Given this list of marker genes INTS8, ZNF395, TUBA4A, PTPRO, SAMM50, MRPL34, PDE5A, MRPS6, MTERF4, SLC25A36, TIGD2, MLLT10, VGLL4, COQ5, LBHD1, AGAP1, SPSB2, HDGFL2, PRMT9, REG1B, PDE4A, TBC1D2, THADA, SLC20A1, NVL, TACSTD2, ARHGEF40, MBP, RHOBTB2, RCBTB2, DCAF8, POLR3A, CCDC107, MRPL58, PAGR1, ABHD10, MBD4, RNF113A, FAM78A, DDX28, TSC22D1-AS1, SEC14L1, KAT14, KRT19, HKDC1, TTC9, TMEM138, CPNE6, SETDB2, MALSU1, SNAP47, ARHGAP12, EHD3, SLC25A30, TRPS1, SNX18, BLOC1S5, CNTNAP4, CIPC, ZC3H14, MPPED2, VSIR, SLC29A3, CIAO1, OLFM3, ORAI3, CNOT8, CTNS, BMPR1A, MCFD2, RASL12, DOK1, COQ3, MRPL35, DNAI4, ZNF420, NMNAT1, LDLRAP1, VAV3, CSTF1, ASB2, SMIM3, RMND1, CDS1, SIAE, KCNE3, RPA1, ELAPOR2, CYREN, GDF10, DGCR2, C2orf74, CYB5RL, MELTF, AKAP14, RANBP6, DAB2, TRIM32, RIN3, DOK3, ZFP3, SDC1, UBE2G1, CEP85, DNTTIP1, PHF23, PDF, FGD4, DHRS9, COQ9, PIP4K2B, POP7, PSTPIP1, KLF12, ZFP64, TNNI2, GYG1, FAM220A, NDUFV3, KIAA0513, ZNF555, MTARC1, TMCC1, DEF8, UPK3A, TBC1D24, FBXO32, GFOD1, CRISP1, ANKMY2, MKX, ZBTB4, HDAC9 (NCBI Gene Id 9734), HOXB13, STEAP1, LINC01565, UBL7-DT, MAPK14, LIPT1, PAFAH2, AIRIM, DAG1, C21orf58, STN1, CYTH4, SLAMF6, METTL23, GIT1, TLR10, INTS10, ITPKB, MAL, METTL17, LINC02487, WDR53, BICD1, PIK3R1, USP2 (ubiquitin specific peptidase 2), CHD9, ENHO, PDE9A, FRMD4A, DEDD2, PRR12, NR0B2, DEFA6, AASDHPPT, SDR16C5, EFNA4, ACAA2, MRPS26, PDE6C, SENP8, RGS19, CALHM2, MIS18BP1, ANKRD39, MCF2, KIZ, F2RL1, CXCR4, SPRY2, STARD7 (NCBI Gene Id 56910), NDRG2, ARAP3, MBLAC2, TACR2, METTL13, TLR6, SOX14, SERTAD2, MAST3, NIF3L1 (NCBI Gene Id 66010), FOS, PCDHGA9, OSGEPL1, IMP3, PRAM1, SLC2A1, ZDHHC24, MTIF3, RAB40B, IRAG2, DKK3, TRIM54, SNAI3, PARP2, RDH13 (retinol dehydrogenase 13), FRAT1, WFDC21P, TNFSF14, GZF1, TBCD, SCML4, KRT18, ATP1A2, MIEF1, NR2F6, FGF7, PLA2G15, IFT70B, ZNF341, GPRASP2, CEP44, AGBL2, BOLA1, SLC25A29, CEP68, NCAPH, CHAMP1, CD300LB, ECI2, YAE1, MRPL18, RCOR3, RUBCNL, CXXC5, MRPS18B, YPEL4, ARL11 (ADP ribosylation factor like GTPase 11), IFFO1, TMEM177, CXCR6, NAA16, FANCE, EXOSC4, COMMD3, KCND1, CCDC9B, THYN1, CARD9, IER5L, LZTS2, PIMREG, A2M-AS1, NTNG1, FAM135A, TIGAR, PLIN2, DGKB, DCP1B, USP3-AS1, LIAT1, TLR1, DBT (NCBI Gene Id 1629, dihydrolipoamide branched chain transacylase E2), HHEX, ZNF444, DENND10P1, MOAP1, TRIAP1, ZNF785, XPC, C1QTNF3, SNAPC5, THUMPD3, ENTPD1, S100A7, TBC1D13, POMGNT2, DGKZ, UBR5-DT, MAGEB6, VGLL3, ST6GALNAC4, C7orf25, MRTFB, LIAS (NCBI Gene Id 94182), IQCF6, UBR7, CEBPA, NFATC3, SYCP1, AVPI1, C11orf21, SARDH, SHLD1, THSD4, HEATR3, TTI1, MZB1, ZNF549, SURF6, MLYCD, GIT2, HENMT1, DDI2, GYPA, CLPX, TIMM29, ATOSA, DPH5 (diphthamide biosynthesis 5), ELOF1 (elongation factor 1), MTF2, RPUSD3, TMLHE, ZBTB14, DIP2A, KNG1, RAB7B, GLS2, FADD, NLRC4, PLCL2, NRG1, FHL1, OTUB2, LINC01521, ARMCX6, MCEE, DNAH9, LPAR6, RWDD2A, ARV1, DPF3, SGK1, HSF1, DUSP7 (dual specificity phosphatase 7), ORC5, PRKD3, HERC2P9, BRAT1, PLAAT1, POLG2, DAGLB, AASDH, GLT8D1, APEX2, SUFU (NCBI Gene Id 51684), TSPY2, TLE3, ALPI, GLRX5, TMEM41A, CALB1, FAM215A, OXLD1, NOA1, PWWP2B, KDM3A (NCBI Gene Id 55818), POLR3K, KLHDC3, CD6, TIGD6, LSM10, MRM2, ZNF362, TMEM107, FRAT2, RNF7, TRMT61B, ZBTB48, CCSAP (centriole, cilia and spindle associated protein), PLK2, ANP32A, GEMIN6, GNAL, here is a description of the gene set: Human Gene Set: ZHOU_INFLAMMATORY_RESPONSE_LIVE_DN species: Homo sapiens from publication Zhou Q, Amar S (PMID 18025224) Genes down-regulated in macrophage by live P.gingivalis. Porphyromonas gingivalis (P. gingivalis) can trigger an inflammatory condition leading to the destruction of periodontal tissues. However P. gingivalis LPS and its fimbriae (FimA) play different roles compared with the live bacteria in the context of intracellular molecule induction and cytokine secretion. To elucidate whether this difference results from different signaling pathways in host immune response to P. gingivalis, its LPS, or its FimA, we examined gene expression profile of human macrophages exposed to P. gingivalis, its LPS, or its FimA. A comparison of gene expression resulted in the identification of three distinct groups of expressed genes. Furthermore, computer-assisted promoter analysis of a subset of each group of differentially regulated genes revealed four putative transcriptional regulation models that associate with transcription factors NFkappaB, IRF7, and KLF4. Using gene knockout mice and siRNA to silence mouse genes, we showed that both TLR2 and TLR7 are essential for the induction of NFkappaB-containing genes and NFkappaB-IFN-sensitive response element (ISRE) cocontaining genes by either P. gingivalis or its purified components. The gene induction via either TLR2 or TLR7 is dependent on both MyD88 and p38 MAPK. However, the unique induction of IFN-beta by P. gingivalis LPS requires TLR7 and IFNalphabetaR cosignaling, and the induction of ISRE-containing gene is dependent on the activation of IFN-beta autocrine loop. Taken together, these data demonstrate that P. gingivalis and its components induce NFkappaB-containing genes through either TLR2- or TLR7-MyD88-p38 MAPK pathway, while P. gingivalis LPS uniquely induces ISRE-containing genes, which requires IFNalphabetaR signaling involving IRF7, KLF4, and pY701 STAT1.